Given this list of marker genes Ift172, Scube2, Ndp, Wnt7b, Runx2, Sall1, Gli2, Prkacb, Dhh, Ift57, Hhipl1, Prrx2, Gpc2, Chsy1, Nme7, Nkx6-1, Tubd1, Boc, Ift56, Ttc21b, Evc2, Ctnna1, Rfx4, Gas1, Chrd, Cdk20, Gpc3, Prkaca, Sall3, Bbs7, Tulp3, Kctd11, C2cd3, Ext1, Herc4, Nsdhl, Iqce, Tctn3, Zfp423, Zic1, Stil, Glis2, Tuba1a, Hes1, Tbc1d32, Efcab7, Cfap410, Cplane2, Wnt9a, Ift140, Ror2, Scube1, Gli3, Ift88, Ptchd1, Fgf9, Ift46, Hhip, Fuz, Foxa1, Pttg1, Fgfr3, Ubr5, Cc2d2a, Tedc2, Tmem17, Cdon, Iqub, Arl3 (ADP-ribosylation factor-like 3), Ihh, Dlg5, Slitrk4, Kif3a (NCBI Gene Id 192824), Kif7, Evc, Cd3e, Hspg2, Wdpcp, Stk36, Dync2h1, Enpp1, Mks1, Ro60, Vcp, Ift20, Nkx2-2, Ift27, Pdcl, Hipk2, Rab23, Tctn1, Mgrn1, Gorab, Nog, Wnt10b, Rpgrip1l, Cibar1, Armc9, Tctn2, Tedc1, Megf8, Ulk3, Isl1, Arl6, Intu, Rab34, Smo, Shh, Septin2, Fbxl17, Fgfr2, Dzip1, 2700049A03Rik, Gli1, Foxf1, Wdr11, Dzip1l, Gpr161 (NCBI Gene Id 240888), Fkbp8 (FK506 binding protein 8), Rb1, Tmed2, Traf3ip1, Tgfbr2, Shox2, Ptpdc1, Actrt1, Uchl5, Ift52, Gas8, B9d1, Disp2 (dispatched RND transporter family member 2), Pdx1, Disp1, Cenpj, Ttbk2, Map3k10, Kctd6, Cluap1, Prrx1, Tmem231, Ptch2, Hes5, Zic3, Txndc15, Por, Wdr19, Foxa2, Sfrp1, Rack1, Ift81, Ptch1, Sufu, Mosmo, Ttc23, Ift80, Hipk1, Fgf10, Skor2, Kctd21, Ift25, Rora (RAR-related orphan receptor alpha), Pax6, Arl13b, Pkd2l1, Ssna1, Dyrk2, Ulk4, Gpr37l1, Ift122, Scube3, Ndst1, Serpine2, Hhat, here is a description of the gene set: Mouse Gene Set: GOBP_SMOOTHENED_SIGNALING_PATHWAY The series of molecular signals generated as a consequence of activation of the transmembrane protein Smoothened. studied in species Mus musculus